The following is a description of a gene set: Reactome Pathway: Cellular responses to stress species: Homo sapiens part of: Cellular responses to stimuli Cells are subject to external molecular and physical stresses such as foreign molecules that perturb metabolic or signaling processes, and changes in temperature or pH. Cells are also subject to internal molecular stresses such as production of reactive metabolic byproducts. The ability of cells and tissues to modulate molecular processes in response to such stresses is essential to the maintenance of tissue homeostasis. Specific stress-related processes annotated here are <b>cellular response to hypoxia</b>, <b>cellular response to heat stress</b>, <b>cellular senescence</b>, <b>HSP90 chaperone cycle for steroid hormone receptors (SHR) in the presence of ligand</b>, <b>response of EIF2AK1 (HRI) to heme deficiency</b>, <b>heme signaling</b>, <b>cellular response to chemical stress</b>, <b>cellular response to starvation</b>, and <b>unfolded protein response</b>., and this is the list of marker genes: MLST8, SERP1, H3C15, SEC13, MED1, H2BC13, DNAJA4, FKBP14, KEAP1, P4HB, HSPB2, CREB3, PDIA5 (NCBI Gene Id 10954), H3-3A, ATP6V1B2, BMAL1, UBE2S, EP400, NUP88, H3-4, RPA2, TERF2, AJUBA, ERO1A, GSK3A, AQP8, BAG5, NCF2 (NCBI Gene Id 4688), MUL1, HIKESHI, CREB1 (NCBI Gene Id 1385), RPS12, RPL39, NUP98, ATP6V1E1, CREBBP, WDR24, UBE2D2, RPL27A, ATP6V1D, CAT, MEF2C, HBA1, PRDX2, HSPA12A, GSTA1, AGO4, EIF2S2, LY96, MAFK, KDM6B (NCBI Gene Id 23135), MYC, TXN, HSBP2, EIF2S3, PHB2, EHMT1, MAPK7, RPL36AL, WIPI1, PSMA3, MIRLET7B, NUP155 (NCBI Gene Id 9631), SKP2, FNIP1, CUL1, SMARCD3, ANAPC10, NPRL2, NFKB1, CARM1 (NCBI Gene Id 10498), NBN (NCBI Gene Id 4683), HSPA8, HSP90AB1, HSPA1A, TXN2, NUP85, EIF2AK4, RPS10, TNRC6C, PSMA7, RPS6, TALDO1, RPS2, SSR1, RPS25 (ribosomal protein S25), H2AB1, RPS27A, GPX8, RBBP4, ATP6V1B1, EDEM1, CUL7, FZR1, RORA, NPLOC4, DYNC1I1, RPS15, DCSTAMP, NUP37, NCF1, H2AZ2, MIR24-1, ALB, GPX5, AAAS (aladin WD repeat nucleoporin), RPS7, ABCC1, ITFG2, RPL14, HSPA2, CRTC2, MAPK14, E2F3, PPP1R15A, RPL23A, ATP6V0D2, EGLN3, TBL1XR1, RAE1, HSF1, H2BC12, TUBA1B, ATP6V1E2, POM121C, TNRC6A, CHD6, PHC2, SEM1, HSPA4L, E2F1, COX4I1, MT-CO2, ATP6V1G3, HIGD1A, EPO, TFDP1, CREB3L4, NOTCH1, RPL28, RPLP2, IL8, TSPYL2, DDIT3, ATP6V1C1, HTRA2, SUZ12, MAPK9, NDC1, HIF1AN, ATF3, PSMD13, NCF4, RPL31, PGRMC2 (progesterone receptor membrane component 2), CCS, NCOA6, LONP1, DNAJC3, RRAGD, MIR155, H2BC26, RPL7, SCMH1, UBA52, DNAJB6, FOS, RRAGC, APOB, MAFG, RPS6KA3 (NCBI Gene Id 6197), TLR4, H2BC9, CREB3L1, TUBA3E, STAT3, RPL8 (ribosomal protein L8), RPL10L, DEPDC5, HSPA13, ATP6V0E2, RPL11, BAG1, IL1A, LAMTOR3, RBX1, HSPB8, GPX2, ASF1A, HIRA, ELOB (NCBI Gene Id 91153), PSMA6, NUP62, H2AC18, DNAJB11, GSR, ABCC3, RPS6KA2 (ribosomal protein S6 kinase A2), EXTL1, ATP6V1C2, MAPK11, BMI1, ARNT, MTOR, CBX2, MAPKAPK5, DYNLL2, ARFGAP1 (ADP ribosylation factor GTPase activating protein 1), XBP1, TNFRSF21, ATP7A, ATF6B, CSNK2A2, DIS3, NR3C1, HSP90AA1, HDAC3, DCTN1, RPS19BP1, ATP6V1G2, DELE1 (DAP3 binding cell death enhancer 1), MBTPS1, MIRLET7C, LAMTOR4, RPLP0, CAPZB, HSP90B1, CRTC3, HIGD1C, PALB2, ELOC, ANAPC2, HIF3A, H2BC21, RPL7A, CAPZA2, HSPD1, RBBP7, NFYA, ANAPC15, EXTL3, ME1 (NCBI Gene Id 4199), NPRL3, RPS28, RPS3A, SP1, ATP6V1G1, DCP2, RPS6KA1, X, HMGA2, KDELR3, NUP35, UBN1, CCNE1, RPS20, GML, UBXN7, ADRM1, RPS23, RANBP2, RPSA, SRPRB, NFYB, HYOU1, RPL23, PARN, TUBA1A, TUBA1C, SOD3, ATP6V0E1, RNF2, CREB3L2, COXFA4, TUBA4A (tubulin alpha 4a), TFDP2, RELA, MIR196A1, CXXC1, TUBB8, TUBB8B, AKT3, NPAS2, CDKN2D, ACADVL, SLC46A1, NUP153, MAPK3, SESN1, RPL18A, ATF4 (NCBI Gene Id 468), FBXL17 (NCBI Gene Id 64839), NUP43, BRCA1, PSMA5, PRDX1, CRTC1, BACH1, PSMA1, H2AC4, ST13, GRB10, UBE2D1, SLC7A11, CCNA1, ATP6V1F, RRAGB, POT1, PTK6, CBX4, TERF1, CASTOR1, SRXN1, RPL26, TBL1X, SYVN1, TXNIP, TERF2IP, NUP107, PSMC1, TPP1, HSPE1, ANAPC1, PSMD2 (proteasome 26S subunit ubiquitin receptor, non-ATPase 2), CLEC1B, DNAJC2, ATP6V0D1, COX4I2, CDC16, LIMD1, EXTL2, DEFA5, H1-0, SESN2, HDAC6, MIR24-2, CCNE2, CCL2, H1-3, H2AC6, HIF1A, EXOSC8, RPL36A, SQSTM1, TNIK, AKT1S1 (AKT1 substrate 1), RPS13, ANAPC7, HELZ2, HERPUD1, CDKN1B, COX6A2, COX7C, CRYBA4, RPL4, IFNB1, ANAPC16, VENTX, STIP1 (stress induced phosphoprotein 1), BAG3, YME1L1, MAP2K7, TCIRG1, COX6B1, SIRT3, TP53, PSMB1, H2BC14, GOSR2, PSMD7, UBE2E1, DNAJC7, NRF1, LAMTOR5, PSMC5, TINF2, MAPKAPK3, TXNRD1, TUBA4B, CDK6, H2BC11, FKBP4, H4C1, DCTN6, NUP160, IMPACT, RPL39L, RPL13, DNAJB1, RPL37A, H2BC1, NUP133, DCTN5, TRIM21, CDK2, NFE2L2, MINK1, CLOCK, FLCN, H2AJ, STOML2, EGLN1, AREG, EIF2AK1, PHC1, H1-2, RPL10, TKT, PDGFA, ATF2, GCLC, RPL18, COX7A2, H2BC4, RPS29, KPTN, JUN, NUP50, ATP6V0C, TUBB1, NUP205, H2BC3, WFS1, RXRA (retinoid X receptor alpha), PGD, NCOR2, CITED2, CAPZA1, RPL37, COX6B2, NOX5, COX5B (cytochrome c oxidase subunit 5B), H1-5, RPL15, MAPK8, HSBP1, H2AC20, ETS2 (ETS proto-oncogene 2, transcription factor), POM121, APOA1, PTGES3, TUBB6, RPS26, NFYC, NUP188, MOV10, ERN1, AR, HSPA6, HSPA12B, H2BC5, AKT1, SERPINH1, PRKAA2, COX5A, RPS4Y1 (NCBI Gene Id 6192), CCNA2, TUBB2B, PRDX5, IGFBP1, CDC27, CUL2 (NCBI Gene Id 8453), H2AC7, NOX4, RPS8, WTIP (NCBI Gene Id 126374), AGO3, TGS1, ATR, RRAGA, GSTA3, HSPH1, SZT2, PSMC4, DYNC1LI1 (NCBI Gene Id 51143), 28S rRNA, PSMB3, HDGF, TUBB3, FABP1, LMNA, MRPL18, TUBA8, EZH2 (enhancer of zeste 2 polycomb repressive complex 2 subunit), FOXO3, PSMB7, YWHAE, HSPB1, MAP2K3, SIN3B, CHAC1, RPS18, CA9, PRDX6, YIF1A, RPL3L (NCBI Gene Id 6123), RPS19, CYBB, NLRP3, MAPK10, ADD1, SAMTOR, AMER1, COX6C, EXOSC6, PSMA4, CEBPG, DYNC1LI2, UBC, PPARGC1A, GCLM, CYCS, PSMD11 (proteasome 26S subunit, non-ATPase 11), RPL12, ACTR1A, DNAJA1, RPA3, PSMB2, VCP, BAG2, PSMD3, PSMB4, UBE2C, CUL3, EXOSC4, CAPZA3, SULT1A3, MAP2K6, CDC26, PSMD12, HMGA1, HSPA1B, VHL, PDIA6, IDH1, RPL24 (NCBI Gene Id 6152), GPX1, PRKCD, ANAPC4, MRE11, RPA1, TUBB4A, SEC31A, NUP210, RPS27, SOD1, ATP6V1A, VEGFA, RPL17, H3C1, MAP1LC3B, LMNB1, PGR, RPS21, NUP93, ABCF2, MEF2D, RING1, PRKCI, CDK4, EXOSC7 (NCBI Gene Id 23016), ID1, IGFBP7, ACD, ATF6, RPS9, RLN1, PSMB6, RPS4X, CHD9, RPS14, CYBA, CDKN1A, HSPA9, RPL10A, CEBPB, ERF, PSMD14, RPL41, CAMK2A, EXOSC2, PSMC6, DYNLL1, FNIP2, RAD50, TLN1, DYNC1I2, PLA2G4B, NRIP1, MT-CO1, LAMTOR1, ATM, CDKN2C, RPL30, HM13, CAMK2B, RPL38, HSPA1L (heat shock protein family A (Hsp70) member 1 like), PSMD8, DYNC1H1, ETS1, CABIN1, NUP42, AGO1, ATOX1, RPL35A, TNRC6B, BLVRB, MYDGF, CALR, COX7A1, UFD1, TUBAL3, EIF2AK3, RAI1, CAMK2D, TUBA3C, PSMD1, BCL2, RPL36, KLHDC3, GCN1, COX6A1, DCTN3, RPL26L1, RPL9, PSMD6, MIOS, CXCL8, MIR98, ANAPC11, HBB, ATP6V1H, EXOSC9, RPL32, RPS15A, GPX7, PRDX3, BTRC, RPS5, TUBA3D, 5S rRNA, RPS17, RPL22L1, SIRT1, KAT5, LAMTOR2, RPL6, DNAJA2, DNAJB9, GPX6, CRYAB, RPS11, H2BC17, EPAS1, MAP3K5, KICS2, BAG4, PSMC3, RPS16, PREB, COX7B, WDR59, OMA1, ANAPC5, CDKN2A, BLVRA, ABCG2, RPS27L, MAPK1, COX8A, SKP1, NCOR1, PSMA2, COX8C, SHC1, CCAR2, RPTOR, RPS4Y2, CDKN2B, HSPA4, SLC38A9, HMOX2, HSPA5, CBX8, HSPA14, H2AC14, RPL35, IL6, ZBTB17, RHEB, MAP2K4, UBE2D3, EIF2S1, PPARA, H2AX, XPO1, FAU, PSMB5, ACTR10, EED, ASNS, CSNK2A1, MDM2, NUDT2, 18S rRNA, RPL13A, HSPA7, EGLN2, DCTN2, STAP2 (NCBI Gene Id 55620), SRPRA, MBTPS2, EEF1A1, DCTN4 (dynactin subunit 4), CDC23, UBB, EXOSC5, H2BC15, GSTP1, EXOSC1, KHSRP, H1-1, RB1, SH3BP4, COL4A6, E2F2, GFPT1, CSNK2B, EGF, 5.8S rRNA, H2BC12L, TRIB3, MAPKAPK2, NR3C2, HMOX1 (heme oxygenase 1), TXNRD2 (NCBI Gene Id 10587), CTDSP2, H1-4, RPL3, CBX6, COX7A2L, CASTOR2, ESR1, TATDN2, PHC3, FKBP5, NCOA1, CREB3L3, G6PD, EXOSC3, PSMC2, TUBB4B, EP300, SOD2, GSK3B, SEH1L, DPP3, RPL34, RPS24 (ribosomal protein S24), DDX11 (NCBI Gene Id 93260), NR1D1, PPP2R5B, CREBRF (CREB3 regulatory factor), TUBB2A, SIN3A, BCL2L1, NCOA2, RPS3, NUP54, MDM4, GPX3, NUP58, TPR, RPL5, RPLP1, CAMK2G, RPL21, NUP214, NQO1, DEDD2, ATP6V0B, MAP4K4, RPL29, AKT2, EHMT2, RPL22, MT-CO3, ATF5, RPL19, RPL27